Given this list of marker genes CYP1B1, CYP2C9, CYP1A1, CYP3A5, CYP3A4, CYP3A7, CYP19A1, CYP2B6, CYP1A2, here is a description of the gene set: Human Gene Set: GOMF_ESTROGEN_2_HYDROXYLASE_ACTIVITY species: Homo sapiens Catalysis of the reaction: estrogen + reduced + O2 = 2-hydroxyestrogen + H+ + H2O + oxidized.